The following is a description of a gene set: studied in species Homo sapiens Human Gene Set: GOBP_MAST_CELL_MIGRATION The movement of a mast cell within or between different tissues and organs of the body., and this is the list of marker genes: KIT, VEGFD (vascular endothelial growth factor D), RIN3, CHGA (chromogranin A), STAT5B, CCL11, PIK3CD, RABGEF1, PGF, KITLG (NCBI Gene Id 780897), VEGFA, RAC2, VEGFC, VEGFB, SWAP70